The following is a description of a gene set: studied in species Mus musculus The chemical reactions and pathways resulting in the formation of estrogens, C18 steroid hormones that can stimulate the development of female sexual characteristics. Also found in plants. Mouse Gene Set: GOBP_ESTROGEN_BIOSYNTHETIC_PROCESS, and this is the list of marker genes: Dhrs11, Hsd17b12, Hsd17b7, Gm2044, Hsd17b1, Cyp19a1, Hsd17b2, Hsd17b8, Star, Bmpr1b